Given this list of marker genes Vcp, Gpd1, Gapdh, Slc25a22, Ogdh, Mdh2, Slc25a13, Foxk2, Foxk1, Slc37a2, Mdh1, Eno2, Eno1, Hk1, Got2, Gpd1l, Nudt17, Pcx, Me1, Dlst, Slc25a12, Pgk1, Nudt13, Slc25a11, Got1, Pfkm, Slc1a3, Hk2, Nudt12, Bcl2l13, Eno3, Gpi1, Slc25a18, Gpd2, Pfkl, Pkm, Pgam2, Eno1b, Src, Pfkp, Aldoa (NCBI Gene Id 11674), Tpi1, Mdh1b, here is a description of the gene set: studied in species Mus musculus The chemical reactions and pathways involving reduced nicotinamide adenine dinucleotide (NADH), a coenzyme present in most living cells and derived from the B vitamin nicotinic acid. Mouse Gene Set: GOBP_NADH_METABOLIC_PROCESS